The following is a description of a gene set: Any process that mediates the transfer of information from one cell to another. This process includes signal transduction in the receiving cell and, where applicable, release of a ligand and any processes that actively facilitate its transport and presentation to the receiving cell. Examples include signaling via soluble ligands, via cell adhesion molecules and via gap junctions. Human Gene Set: GOBP_CELL_CELL_SIGNALING studied in species Homo sapiens, and this is the list of marker genes: CELA2A, NRG3 (NCBI Gene Id 219505), CCL7, LYPD1, IL2, IL36G, PTPRN, HTR2C, BMP6, GPNMB, FOXD1, LRRTM2, KCNN2, USP46, PFKL, FZD2, NOS1, NPY5R, GABRD, FGF17, IHH, HNF1B, CCL17, MYB, GRIK5, ADORA2B (NCBI Gene Id 136), TNFSF9, SCN10A, APP, SHANK3, CAMK2G, RAB8B, PLK2, PHF24, NPPA, HNF4A, FGFBP1, CCN6, CFTR, CPEB3, FGFR1, IL1RAPL1, GRAP2, GPRC6A, FCRL2, OXT, TRPM5, GABRG2, GRID2, F2, PLG, RPS6KA1, RPH3AL, DTNA, CACNA1G, CHRNE, CHST4, SYNGAP1, CACNA2D1, SYT11, RAPGEF2, CALHM2 (NCBI Gene Id 51063), HCRT, BHLHA15 (NCBI Gene Id 168620), ACVR2B, CX3CL1, SLC24A1, PMP22, CBLN4, SH3KBP1, NFATC4, TMED1, FGF11, ISL1, GRM6, OPRM1, IFNA2, GUCY1A1, CA7 (NCBI Gene Id 766), SMO, PFN2, SYTL4, EPHA7, PTCHD1, SLC8A2, STX11, ACVR1C, HTR1F, CLSTN3, XCL1, HOMER1, SYT1, FOXA2, SOX11, ADIPOQ, S100B, TPGS1, GIT1, F2RL1, CCL3, KCNQ2, CCL26, POMC, P2RX5 (purinergic receptor P2X 5), HES1, C1QTNF1, RAC3, RBP4, FBXL20, TRPV4, ABCA1, CARTPT, NGFR, FFAR4, DBN1, TBX5, NKX3-1, MPC2, GSG1L, GJB6, C2CD2L, DLG2, CD34, EZH2, BCHE, GJB4, BACE1, SCN1B, GRID1, AP2B1, PPP3CB, AQP1, APBA2, FXR2, SNX14, FAAH (NCBI Gene Id 2166), NR1D1, GRAP, SLC12A5, CACNA1E, YWHAH, SLC30A1, HILPDA, FZD4, ABTB3, LRP6, UNC13B, CCL2, GRIK4, CYB5R4, FGF2, ADORA3, BMP8A, GABRB1, HRH4, OPHN1, HCN1, ALOX5, TRPV1, ELFN2, PTGES (prostaglandin E synthase), FFAR3, PPP3CA, GRM3, CLN3, MTNR1B, KCNK2, SYT8, PCDHB6, HTR1E, TRPA1, PLCL2, OSBP, GNA11, RPS6KB1, SRI, FBXO45, SYP, PRKCG, ARHGAP44, HRH1, CBLN2, VDAC1, CHRNA7, EPHA4, GAL3ST4, CACNA1D, ENY2, AKT1, GABRA6, STXBP2, UQCC2, MCTP2, GJB3, KCND2, HRAS, SPG11, CELF4, IL17A, GPR176, EXOC4, NOS2, FGF18, EIF4A3, GRIN2C, NGF, ATP2A2, FOXO1, MIDN (midnolin), RAB8A, SHISA7 (NCBI Gene Id 729956), TUNAR, ATG5, TCF7L2, CHRNB1, GJC1, GPLD1, PANX2, VPS18, SYNGR3, PCDHB13, GDF5, TMEM25, TRHDE, UCN3, KPNA1, PDGFB, CPLX2, ENSA, SNAP25, BSN, KCNK3, LZTS1, GRIN3B, EFNA2, PHPT1, P2RX2, VIPR2 (NCBI Gene Id 94613), HFE, GAL, SLC9B2, GNRH1, GRIN2B, CEP89, RAB11FIP1, PGR, GHRL, PPP3R1, GABRA5, MICU3, WNT5A, USP14, FYN, BEGAIN, CYFIP1, LAMA2, KAT2A (NCBI Gene Id 2648), GRM1, NOTCH1, FBXO41, CPE, CALCA, JAK2, CBLN1 (cerebellin 1 precursor), ADGRB1, PTPN11, VAMP3, CHRNA1, GRIN2D, SLITRK5 (NCBI Gene Id 26050), GSK3B, PORCN, AKAP9, GJD2, LRRTM1, RAPGEF3, LRP5, HGF, SYT9, NPS, PRKN, CLSTN1, PRNP, SDCBP, GPR68, NLGN3, CCN3, CXCL9, SLC1A1, INSYN2A, MYOF, MME, PRKCZ, BTBD9, WNT2, FCHSD1, KCNJ10, INHA, SLC18A2, CDK16, PCDHB5, CADPS, PTGS2, ARC, SREBF1, TYROBP, MBP, SELENOM, MIR433 (microRNA 433), ITGB1 (integrin subunit beta 1), GJB2, RELN, PDYN, GRM7, NMB, CXCL10, MAPK8IP2, GJB7, HTR3E, WNT6, ADNP, FBXO2, SERPINB3, CRY1, ESR2, FMR1, MIR320B2, PFKM, TAC1, HCN2, TP63, ASIP, F2RL2, EFNA4, GABRA4, ZDHHC12, NEUROD2, CCL18, KCMF1, TOR1A, CACNB3, FGF12, TARDBP, OTOF, LILRB2, HTR3B, TPBG, BAIAP3, STXBP4, CRHR1, SSTR3, RAB1A, CCN4, ITPKA, STX2, ADGRG1, SLC16A2, CCL4, SSTR5, CRH, NPBWR1, PLPPR4, ETV5, SLC29A1 (NCBI Gene Id 220811), PTEN, NTF4, RAPSN, KCNJ11, CACNA1B, JPH3, C22orf39, DKK1, DTNBP1, LHX1, IAPP, EPHB1, PAFAH1B1, FJX1, P2RY1, HOXA5, KCNE5, GNAT1, FARP1, GNAI2, CASQ2, CALM1, SLC12A7, STX4, SIDT2, SLC6A5, IL1RAP, PCDHB3, CDH8, FFAR2, SYPL1, SLC8B1, ADGRE5, EFNA5, MAPK9, HTR4, MIR208A, GDF15, GLUD1, TNFRSF1B, MYLK2, NUDT3, SHH, CGB7 (chorionic gonadotropin subunit beta 7), GNB1, CCL15, VAMP7, GPR156, RAB11FIP2, ADRB2 (adrenoceptor beta 2), PLA2G4A, PCDHB11, C1QTNF12, PPFIA2, CHRM5, FGFR2, FGB (NCBI Gene Id 2244), PTHLH, DLGAP1, PKP2, TM7SF3, CTF1, CHRDL1, MLXIPL, CHMP2B, GCG, GPER1, ACE, PRKAR1A, SYT2, CHRNA3, RAB5A, PRKCA, ORAI1, AGER, ZDHHC3, VAMP8, GNRHR, DNAJC5, HLA-DRB1, ANK2, CPLX1, MC4R, PPFIA3, KIF5A, SCN5A, SYT4, CHRNA6, MIR320A, GATA4, CA2, CGAS, HTR1D, SFRP2, DYSF, SLC2A2, FGG, MIR342, TPRG1L, SYN2, PIP5K1C, CREB1, GRIN3A, SMAD2, TNFRSF11A, GLRA3, MECP2 (NCBI Gene Id 8274), TFR2, GRM4, KCNJ5, P2RX1, SYNGR1, GABRB2, P2RX6, APBA1, SIGLEC6, CACNA2D2, LHB, CASK, FADS1, PGF, ZBED6, BMAL1, ABCA12, ERC2, C1QA, VIP, DLGAP2, CCL13, SYBU, ELFN1, CCL23, SIRT4, MIR337, BEST1, NF1, RAB11FIP3, UNC119, CACNG8, TACR1, NCDN (NCBI Gene Id 23154), EDN1, LRRK2, EFR3A, FOXA1, IRS1, PANX1, F2R, IGSF21 (NCBI Gene Id 84966), SV2B, CDC20, ARRB2, IFNG, SYT13, SHISA6, ACP1 (acid phosphatase 1), STX19, TNF, CLOCK, AGRN, CFL1, ZDHHC2, GJD4, LY6S (NCBI Gene Id 124906792), FGF7, MAPK3, NKX6-1, GPR27, PFN1, GABRG1, IL1B, GHRHR, NPVF, GAD2, HCAR2, KIT, CNRIP1, SLC4A8, NRXN2, RAB11FIP5, HTR2A, ADRA1A, RFX6, KCND3, NR1H4, INS, ALDH5A1, NOG, CNTN2, TCIRG1, ANXA1, PCDHB14, PSCA, LRFN2, PCDHB2 (protocadherin beta 2), SNAP23, DMPK, NPTN, PCDHB10, FFAR1 (NCBI Gene Id 2864), LIN7B, GRP, NPTX2, SLC7A10, SUCNR1, ADCY1, MAP1A, HTR5A, FRRS1L, FABP5, RPS6KA2, SCT, PMCHL2, SHANK2, ATXN1, DOC2A, SNAP29, PRKAR2B, KCNA5 (NCBI Gene Id 3741), DTNB, IL15, ANO1, FZD1, TSPOAP1, AFDN, ATAD1, TOR2A, IGF1, PTGIR, CHRM1, RNF10, NEFH, GJA9, SLC17A8, CACNG2, FGF16, ANGPTL2, IRS2, RNF167, TMEM132A, SLC32A1, DSCAM, GJB1, CCL27, HNF1A, RGS8, KCNK9, CXCL5, GRM8, UTRN, PTPRS, SLC12A4, SYT3, PSMD9, COLQ, AKAP5, GABRB3, GRM5, CALB1, ADRA2B, CORT, DLG3, CALM3 (calmodulin 3), CHRNA2, GNAQ, CACNB2, ZYX, PDZD11, EDNRB, BRSK2, SCN4B, CD68, NNAT, DAB2, MPZL1, RELA, SLC8A3, CHRNB4, MYRIP, CACNG7, MIR320B1, RPH3A, LIN7C, CDK5R1, LARGE1, SNX6, ZDHHC17, CACNG3, RASGRF1, CHRM4, NRP1, GATA3, CAMK2A, CXCL12, BMP2, NEFL, IL6, CCL22, MEF2C, ILDR2, KCNJ3 (NCBI Gene Id 3760), SCTR, S100A8, KCNMB1, SIRPG, NAPA, SRF, CCKAR (NCBI Gene Id 886), RAB44, LILRB1, MCTP1, KLF7, SCN3B, UTS2, NLGN4X, CHRNB3 (cholinergic receptor nicotinic beta 3 subunit), SCRIB, NADK (NCBI Gene Id 65220), PRKD1, SLC6A6, EIF2AK4, PDE7B, GABARAP, CNIH2, SORCS2, ADRA1D, CHGA, NALCN, GJA5, SLC24A2, GJC3, SEMA3B, UBE3A, TNFAIP6, TRPM4, ABCC8, SOX4, GRK2, GHRH, RGS4, APBA3, AREG, AGTR1, NTSR1, FAM107A, RAP1B, TEK, GRIK1, CCL16, MAFA, GLP1R, IL3, SEMA4F, CHD7, TRH, FKBP1B, CCL21, SNX19, UCP2, NCSTN, NTRK1, ACP4, PVALB, MIR95, MPZ, GJC2, CCL5, PANX3, CNR2, NXPH1, EFNA3, RARA, ADRA2C, GRIN1, FAT1, STX1B, TGM2, KCNQ3, CGA, STAB1, GABRR1, MIR545, GLRA2, MIR320D2, FGA, SNPH (syntaphilin), HADH, GSK3A, USP8, PPARG, PTPRN2 (NCBI Gene Id 5799), KCNJ8, CDH1, MDM2, GABRA3, AIMP1, MINK1, CHRNA9, OR51E2, LRRC4, PSEN1, CPT1A, SLC5A7, MYCBPAP, HTR1A, HRH2, KCNMB4, CYP19A1, SNAPIN, FCER1G, KIF1B, HCN4, FGF14, NPR2, GJD3, UBE2I, CNR1, BGLAP, SLC30A8, CLSTN2, HTR2B, OPRL1 (NCBI Gene Id 4987), G6PC2, BLOC1S6, JPH4, HCRTR1, NPY, SEMA5A, GJA8, IL17B, FXR1, IL26, FGF20, ECE2, STXBP1, CLMP, GJB5, LRIT1, PRKCB, SV2C, ADRA2A, RIC3, FGF13, SLC16A10, UBE2Q1, SLC1A2, SYT12, NODAL, EIF4E, TBX3, NR0B2, ADAM8, CD38, CRB1, CNP, CRHBP, NXPH4, CACNA1C, SLURP2, FLOT1, CRY2, BRAF, LY6G6D, ADAM17, CHAT, EPHA5, CALM2, CCDC186, RPS6KA3, SERP1, DLGAP4 (NCBI Gene Id 22839), GPR151, RIMBP3C, TMEM108, PCDH17, SMAD4, PICK1, P2RX3, LRP8, HAP1, GLS, DYNLL1, AKAP12, LPAR3, PKP4, ADARB1, RTN4, EIPR1, MIR421, SYN3, PCK2, GRIK3, ALS2, RBM4, FGF22, KCNA2, SLC38A2, FGF9, NPY2R, DLG4, RAB3GAP2, MIR320E, PDLIM4, HDAC6, AR, GFAP, AMH, SELENOT, ACHE, SIRT3, PTN, COMT, KCTD13, SLITRK4, ACSL4, DGKE, AGT, RAPGEF4, OXCT1, CX3CR1, ADORA2A, VDAC3, GNA15, TSHB, GPRIN3, RIMS3, YTHDF1, CXCL11, LY6E, DRD5, NMU, SNCG, CSPG5, SLC1A4, TH, BAD, PER2, CD2AP, RGS14, KCNIP1, PIM3, CCR1, LNPEP, SV2A, NTNG1, CACNB4, INA, P2RX7, GRIA1, NDUFAF2, HMGCR, DBH, ADCY5, GABRG3, GRIA3, POU5F1 (NCBI Gene Id 7934), GNAO1, LIF, EFNB1, PIANP, S1PR2, SNCB, GNAZ, SLC1A3, SRD5A2, CAMKV, HIP1, CRHR2, SLC38A1, SLC12A2, LGI1, PMCH, LGMN, VSNL1, CACNB1, RASGRF2, NR2E1, REST, MIR541, PDE9A, ADCY8, NEO1, ANAPC2, TNC, NEURL1, DRD2, ANXA9, IL1RN, FGFBP2, STAU2, CCL20, WNT1, RASL10B, OSM, RIMBP3B, ITPR1, BCR, EDN3, PRKACA, PCDHB4, SLC44A4 (NCBI Gene Id 87892), CHRNA5 (NCBI Gene Id 1138), HMGA2, PARK7, EREG, DLG1, FGF5, CCL24, CRKL, TFAP2C, ARF1, KCNB1, MIR328, ITSN1, PCDH8, PLA2G3, NPAS4, PENK, MERTK, GUCA1B, SLC4A10, STAC3, PACSIN2, OPRK1, RIMS4, BMP4, PFKFB2, RASD2, INHBB, TSHZ3, KMT2A, LTBP4, TSHR, TBC1D24, CHRNG, VPS13A, PPP1R9A, TNFSF10, RANGRF, UCN, HTR1B, GRIN2A, GLRA1, NQO1, SHISA8, CACNA1A, IL17C, RAB11A, SLC6A1, STAU1, DVL1, PCSK1, SQSTM1, CLCN3, TNFSF8, INHBA, CXCL14, SYT5, KIF5B, BMP3, DAGLA, CHRNB2, CNTN4, INSL4, FOXL2, SPP1, DRD1, CAMK2D, TACR2, DLGAP3, PTPN23, PLCL1, CPLX3, SLC6A4, SCN2B, RIT2, RAB11B, KCNQ1, GABRA1, SNCAIP, SYNJ1, PTH, SEZ6, DOC2B, VPS35, PLA2G10, ABCC4, KCNK16, ECRG4 (NCBI Gene Id 84417), CCR5, LHX5, FGFBP3, CNTNAP4, BCAS3, DLL1, STXBP5, CADPS2, STAT3, DCC, TENM2, RETN, LIN7A, SLC16A1, STX1A, HTR3C, GNAI1, CLTRN, RAF1, GDNF, CXCL13, SYAP1, CHRM2, LY6H, PAX8 (NCBI Gene Id 7849), NLGN2, EFNA1, FLNA, CXCL6, KPNA4, PLP1, PNOC, GALR3, GIP (NCBI Gene Id 2695), CCN5, RIMBP2, RYR2, GPR50, EIF4EBP2, FER1L5 (NCBI Gene Id 90342), MET, PRRT1, CHRNA4, DRP2, SST, APLN, SLC1A6, CHRNA10, FOXL1, STX3, FGFR3, AACS, ATF4, GJE1, NPFF, PLCB1, LEP, BARX1, NSMF, PRR7, NMUR2, CDKL5, GABRR2, EFNB2, DHH, CASR, LAMP5, MPP2, PASK, GABBR1, TSPAN32, PREPL, PCDH1, LTB, UNC13A, TBX18, GIPR, PPT1 (palmitoyl-protein thioesterase 1), KRAS (NCBI Gene Id 3845), CDK5, NRN1, SYT7, AMPH, GABRR3, AVP, TNR, PINK1, ADCYAP1, RAB3A, MIR320C2, SLC1A7 (solute carrier family 1 member 7), SYT6, HIF1A, SIRT6, SNCA, NIBAN2, MIR320D1, CXADR, S100A9, MCU, RFX3 (NCBI Gene Id 5991), WNT2B, PNKD, NUP155, EEA1, GPR119, SYT10, ASIC1, SLC7A11, RIMBP3 (NCBI Gene Id 85376), WNT3A, SLC18A3, PAIP2, ABL1, SLITRK3 (SLIT and NTRK like family member 3), BRSK1, FCHSD2, DRD4, LRRC8A (leucine rich repeat containing 8 VRAC subunit A), ITPR3, KLF10, HCRTR2, ITGB2, PRKAR1B, NETO1, BAIAP2, EXT1, HTR3A, NEUROD1, OSBPL2, RAP1BL, GRIK2, ABR, NAPB, ABAT, GIPC1, PTK2B, VGF, SORCS3, KMO (NCBI Gene Id 8564), GABBR2, TUBB2B, EPHB2, GDF9, CCR2, SMPD3, NSG1, RAC1, ATXN3, NTNG2, INSYN1, SERPINE2, CNIH3, SNX4 (sorting nexin 4), TM2D3, RAB3GAP1, NAMPT (nicotinamide phosphoribosyltransferase), NTF3, TNFSF11, GPR158, HTR6 (NCBI Gene Id 92230), HRH3, UNC13C, GJA10, RAP1A, DYTN, YWHAG, SLC6A3, P2RX4, PRKCE, PCLO, GRIA4, LYN, CTNNB1, SLC12A6, TMF1, EGR3, CPLX4, TRPV6, ENPEP, SH2D1A, GABRA2, PLA2G6, ILDR1, LALBA, SLC25A22, TSPO, KDM5B, FGF3, CHRM3, NTRK2, GRM2, INSL3, CACNG5, ADAM10 (ADAM metallopeptidase domain 10), SLC6A9, GNAS, SNAP47, GABRE, HTR7, CYP46A1, SYN1, GATA1, FAM3A, TFAP2B, NPPC, FASLG, GALR1, MAPK1, FAM3B, REN (NCBI Gene Id 5972), ABHD6, SHANK1, EFNB3, CCL8 (NCBI Gene Id 96488), GJA4, FGF23, WNK4, VPS54, GAD1, GRIA2, MIR324, CDH11, FAM3D, GRID2IP, NRXN1, LRRC4C, CD33, PPARD, EXOC3L1, ATP1A2, FGF4, PTPRD, NLGN1, SCG5, MIR320C1, APOE, GREM1, TRIO, VAMP2, PCDHB9, IL18, PDX1, FGF21, PDE8B, CGB3, PLAT, IL11, STXBP3, MIR30B, CHRFAM7A, RGS10, HAPLN4, SHISA9, C1QTNF3, GGCX, LYNX1, KCNIP2, FGF10, THY1, CHRND (cholinergic receptor nicotinic delta subunit), KCNC4, MTMR2 (myotubularin related protein 2), IL7, IGSF11, WNT7A, LTA, CALB2, TNFSF18, SLC6A2, CAMK2B, MIF, TMOD2, CUX2, PCSK5, RIMS1, NR3C1, NRGN, HCN3 (hyperpolarization activated cyclic nucleotide gated potassium channel 3), GJA3, NPTX1, SLC17A6, ZMYND8, RIMS2, PRRT2, PHEX, CAPN10, GLRB, ADORA1, MIR142, DISC1 (NCBI Gene Id 80138), OMP, KCNN1, CACNG4, DMD, LRIT3, BDNF, DAG1, IQSEC2, JAGN1, AKAP7, GCK, WLS, PDGFA, BTK, GHSR, BLK, SSH1, PCDHB16, SYK, RAB3B, GJA1, MAPT, IFNA7, MAP1B, PXK, SLC17A7, SEPTIN5, HTR3D, DRD3, SIPA1L1, ADRA1B